Given this list of marker genes Mup19, Mfsd13b, Palmd, Kcnk5, Exo5, Elapor1, Hdhd2, Mup12, Zbtb11, Rflna, Nxpe3, Cldn1, Raet1e, Fam89b, Zfp704, Rad21, Arhgef3, Dnajc8, Med27, Il18r1, Mup9, Fam13c, Acss3, Siva1, Fgf13, Mbd3l2, Galnt6, Eml2, Mup1, Raet1d, Strn, Dner, Syt10, Adamts6, Tafa1, Ccp110, Creb3, Mup8, P4ha3, Mthfd1l, Chsy1, Itga4 (NCBI Gene Id 16401), Bmerb1, Stambpl1, Ptpra, here is a description of the gene set: from publication Chen Y, Wang X (PMID 31504780) Mouse Gene Set: MIR_12195_5P species: Mus musculus Genes predicted to be targets of miRBase v22 microRNA mmu_miR_12195_5p in miRDB v6.0 with MirTarget v4 prediction scores > 80 (high confidence targets).